The following is a description of a gene set: The set of processes resulting in differentiation of theca and granulosa cells into luteal cells and in the formation of a corpus luteum after ovulation. Human Gene Set: GOBP_LUTEINIZATION species: Homo sapiens, and this is the list of marker genes: RETN, STAT5A, INHBA, PDGFRA (NCBI Gene Id 5156), PLEKHA1, SGPL1, STAT5B, FZD4, MMP2, GDF9, NR5A1, PTPRN